Given this list of marker genes FGFR1, AKT1, AKT3, AKT2, FGFR2, PIK3CB, PIK3CA, PIK3CD (phosphatidylinositol-4,5-bisphosphate 3-kinase catalytic subunit delta), MTOR, here is a description of the gene set: studied in species Homo sapiens Human Gene Set: KEGG_MEDICUS_VARIANT_AMPLIFIED_FGFR_TO_PI3K_SIGNALING_PATHWAY Pathway Definition from KEGG: FGFR* -> PI3K -> PIP3 -> AKT -> MTOR Amplified FGFR to PI3K signaling pathway. Pathway ID: N00038. Pathway type: Variant. Pathway class: nt06261 Gastric cancer.